Given this list of marker genes eltA, dsbA, hlyA, sta3, hbp, sta2, sta1, gspS2, degP, eltB, secY, gspC2, bamA, acrD, secE, secA, fkpA, hlyB, bamE, macB, bamB, lepB, hlyD, skp, hlyE, secG, gspD2, tolC, bamD, macA, acrB, surA, bamC, acrA, here is a description of the gene set: studied in species Homo sapiens Reactome Pathway: Secretion of toxins Toxins are the virulence factors with the strongest direct effect on host metabolism. Expression of a toxin, together with its secretion machinery, changes any commensal organism into a pathogen. In enterobacteria, toxin and supportive genes can be located on the chromosomal genome or on a plasmid. In both cases they can also be part of a provirus. This means for most toxins that virulence is transferable, and its taxonomic range depends on the taxonomic specificity of the respective mobile element.<br><br>Several types of toxins are found in enterobacteria. Heat-labile enterotoxins (LT) belong to the AB5 type of toxins present in many pathogens outside the enterobacteria, forming a heterohexamer protein complex. Heat-stable enterotoxins (ST) in contrast are small protein monomers. Genes of most members of both toxin types can be found on mobile elements, and are not restricted to specific strains. Export of LT through the bacterial outer membrane is facilitated by the type II secretion system (Mudrak & Kuehn, 2010). ST proteins get exported by an efflux-pump complex containing the TolC pore.<br><br>Mechanisms of enteropathogenic E.coli toxicity to the host cell include activation of adenylate cyclase by LT and of guanylate cyclase C by ST, causing the opening of ion channels and subsequent diarrhea. Extraintestinal pathogenic E.coli strains may also secrete proteases; their host interactions are largely unknown. part of: Infection with Enterobacteria